The following is a description of a gene set: Human Gene Set: GOBP_NEGATIVE_REGULATION_OF_ANTIGEN_RECEPTOR_MEDIATED_SIGNALING_PATHWAY Any process that stops, prevents, or reduces the frequency, rate or extent of signaling pathways initiated by the cross-linking of an antigen receptor on a B- or T cell. species: Homo sapiens, and this is the list of marker genes: BTNL2, SLA2, BTN2A2, PAWR, PLCL2, THY1, PTPN2, CBLB, EZR, ITPRIPL1, CEACAM1, BTRC, PRNP, PVRIG, LPXN, CSK, PTPN6, ELF1, DGKZ, PTPRJ, DUSP3, DUSP22, SH2D1A, LILRB4, FCRL3, PTPN22, MIR34A, FCGR2B, LAPTM5, NCK1, GPS2, CD72, CD22, LGALS3, CD160, PHPT1, GBP1, UBASH3A, CD300A